Given this list of marker genes RET, BFSP2, HTR7, CXCL8, GRIA1, ATP2B2, RASGRP1, SEMA3D, KLHL23, STUM, VAT1, PCDH7, DEFA6, TBX5, PMP2, CHST1, POU1F1, ATP2B4 (ATPase plasma membrane Ca2+ transporting 4), NR4A1, ZBTB22, CXCL1, TLL2, IGF1R, SIK1, WIZ, BCL2L11, FUT9, HLF, TFRC, PTPN11, NFIA, MBTPS2 (membrane bound transcription factor peptidase, site 2), AFF2, IL6ST, SOX5, PPP1R13B, IL6, FGFR3, BRD3, GPR18, FSCN2, IL24, CLGN, IGFBP5, MFAP3, ONECUT1, MAZ (MYC associated zinc finger protein), MT4, NDST1, CXCL2, UBE2B, here is a description of the gene set: species: Homo sapiens Genes up-regulated in primary fibroblast cell culture after infection with HCMV (AD169 strain) at 1 h time point that were not up-regulated at the previous time point, 30 min. Human Gene Set: BROWNE_HCMV_INFECTION_1HR_UP The effect of human cytomegalovirus (HCMV) infection on cellular mRNA accumulation was analyzed by gene chip technology. During a 48-h time course after infection of human diploid fibroblasts, 1,425 cellular mRNAs were found to be up-regulated or down-regulated by threefold or greater in at least two consecutive time points. Several classes of genes were prominently affected, including interferon response genes, cell cycle regulators, apoptosis regulators, inflammatory pathway genes, and immune regulators. The number of mRNAs that were up-regulated or down-regulated were roughly equal over the complete time course. However, for the first 8 h after infection, the number of up-regulated mRNAs was significantly less than the number of down-regulated mRNAs. By analyzing the mRNA expression profile of cells infected in the presence of cycloheximide, it was found that a minimum of 25 mRNAs were modulated by HCMV in the absence of protein synthesis. These included mRNAs encoded by a small number of interferon-responsive genes, as well as beta interferon itself. Cellular mRNA levels in cytomegalovirus-infected cells were compared to the levels in cells infected with UV-inactivated virus. The inactivated virus caused the up-regulation of a much greater number of mRNAs, many of which encoded proteins with antiviral roles, such as interferon-responsive genes and proinflammatory cytokines. These data argue that one or more newly synthesized viral gene products block the induction of antiviral pathways that are triggered by HCMV binding and entry. from publication Browne EP, Wing B, Coleman D, Shenk T (PMID 11711622)